Given this list of marker genes ATP5ME, ATP5MF, NDUFA2, NDUFA5, COX5B, ATP5F1E, ATP5F1B, NDUFA4L2, COX7A2, UQCRFS1, UQCRC2, COX6C, NDUFS3, CBARP, GATB, SDHD, ATP5MG, TBCB, NDUFA10, COX4I1, COX11, SURF1, CYC1, NDUFC1, NDUFS2, NDUFB6, UQCRC1, ATP5MC1, ATP5PO, ATP5MC3, MBD3, SDHB, SDHC, NDUFS6, NDUFC2, CYB5A, BCL2L1, NDUFB7, NDUFB3, NDUFS8 (NADH:ubiquinone oxidoreductase core subunit S8), BCS1L, NDUFA7, NDUFB8, ATP5F1D, SURF2, UQCR10, NDUFA1, NDUFS4, COX7A2L, TMCO6, UQCRB, NDUFB5, ATP5PD, NDUFAB1, COX8A, NDUFB1, NDUFS1, NDUFA9, NDUFS5, NDUFS7, ATP5PF (ATP synthase peripheral stalk subunit F6), COX7A1, COX6A2, COX6A1, NDUFA3, UQCRH (ubiquinol-cytochrome c reductase hinge protein), NDUFA6, COX5A, CYCS, ATP5MC2, UQCRQ (ubiquinol-cytochrome c reductase complex III subunit VII), SDHA, NDUFB4, COX7B, BEX3, COX15, NDUFA4 (NDUFA4 mitochondrial complex associated), COX6B1, NDUFA13, CNOT7, ATP5PB, UQCR11, ATP5F1C, NDUFB2, NDUFA8, COX10, COX7C, here is a description of the gene set: Genes involved in oxidative phosphorylation; based on literature and sequence annotation resources and converted to Affymetrix HG-U133A probe sets. species: Homo sapiens from publication Mootha VK, Lindgren CM, Eriksson KF, Subramanian A, Sihag S, Lehar J, Puigserver P, Carlsson E, Ridderstråle M, Laurila E, Houstis N, Daly MJ, Patterson N, Mesirov JP, Golub TR, Tamayo P, Spiegelman B, Lander ES, Hirschhorn JN, Altshuler D, Groop LC (PMID 12808457) Human Gene Set: MOOTHA_VOXPHOS DNA microarrays can be used to identify gene expression changes characteristic of human disease. This is challenging, however, when relevant differences are subtle at the level of individual genes. We introduce an analytical strategy, Gene Set Enrichment Analysis, designed to detect modest but coordinate changes in the expression of groups of functionally related genes. Using this approach, we identify a set of genes involved in oxidative phosphorylation whose expression is coordinately decreased in human diabetic muscle. Expression of these genes is high at sites of insulin-mediated glucose disposal, activated by PGC-1alpha and correlated with total-body aerobic capacity. Our results associate this gene set with clinically important variation in human metabolism and illustrate the value of pathway relationships in the analysis of genomic profiling experiments.